Given this list of marker genes IGLV1-44, PRKACG, IGLV4-3, ITPR1, IGLV3-25, IGKV1-16, IGHV4-59, IGKV3-15, IGHV3-33, IGKV1-5, IGKV2-28, IGHV2-70, ITPR2, IGKV2D-40, IGKC, IGHV7-81, ADCY1, ADCY4, ADCY6, IGLV1-36, IGKV2-30, IGLV7-46, IGLV3-22, IGHV3-48, CALM1, CD3G, IGKV1D-12, PRKAR1B, IGHV, IGLC7, PRKACB, IGHV3-30, FCGR2A, YES1, FCGR1A, FCGR3A, IGKV4-1, IGKV3-20, PLCG1, IGHG2, IGLV3-21, IGKV1D-39, IGLV5-37, IGKV3-11, PRKAR2A, IGLV2-14, IGLC3, IGHG3, IGLV1-40, FGR, IGLV, IGHV3-13, IGLV4-60, ADCY7, IGHV3-53, IGHV3-11, IGLV1-47, PRKAR1A, ADCY8, SYK, IGLV8-61, IGHV4-39, IGKV2D-30, IGKV2D-28, IGHG4, AHCYL1, IGLV10-54, IGLV2-8 (immunoglobulin lambda variable 2-8), IGHV1-2, LYN, IGHV3-9, IGLV2-11, IGHG1, IGHV1-46, IGHV2-5 (immunoglobulin heavy variable 2-5), PRKX, IGKV2-29, IGKV5-2, ADCY2, IGLV5-45, LPG1G2, ADCY9, IGLV2-18 (NCBI Gene Id 28814), IGHV1-69, IGKV1-39, IGLV7-43, SRC, IGLV3-12, IGKV3D-20, PLCG2, IGHV3-23, IGKV1D-33, ITPR3, IGKV1D-16, IGKV1-33, IGHV3-7, HCK, IGHV4-34 (immunoglobulin heavy variable 4-34), IGLV3-19, IGLC1, IGKV1-12, ADCY5, IGLV2-33, PRKAR2B, CD247 (NCBI Gene Id 919), FYN, IGLV6-57, ADCY3, IL10, IGKV1-17, IGLV4-69, IGLV3-16, IGLV11-55, CREB1, PRKACA, IGLV2-23, IGLC6, IGLC2, IGLV3-27, IGLV3-1, IGLV1-51, here is a description of the gene set: Reactome Pathway: FCGR3A-mediated IL10 synthesis species: Homo sapiens part of: Anti-inflammatory response favouring Leishmania parasite infection Interleukin 10 (IL-10) is an important immunoregulatory cytokine produced by many cell populations; in macrophages it is induced after the stimulation of TLRs, Fcγ receptors or by the TLR-FcγR crosstalk (Vogelpoel et al. 2014 & Saninet al. 2015). Classically, its function is considered to be the limitation and termination of inflammatory responses and the regulation of differentiation of several immune cells. There is increasing evidence of the role of IL-10 in parasite infection outcomes either as a protective or a pathological mediator. In the context of the parasitic disease cutaneous leishmaniasis, Leishmania amastigotes opsonized by IgG induce IL-10 response through FcγRs, which in turn supresses the killing mechanisms in phagocytic cells..